Given this list of marker genes JPT1, RAN, DBI, RPS7, POMP, TMSB10 (NCBI Gene Id 9168), PSME2, PPIA, ANXA2, COX6B1, ATP5ME, NPM1, SUB1, TXN, SSR3, CLIC1, POLR2L, ATP5PO, ATP5MC3, NME1, NOP10, GLRX, SEC61B, LSM3, COX6C, SNRPG, PPIB, BTF3, PDIA6, TMA7, CHCHD2, NDUFS5, HMGB1, COX7A2, IGHA1, SNRPD2, ATP5PF, PPA1, H2AZ1, NDUFB3, COX7B, ATP5MF, CYCS, HSPE1, JCHAIN, SSR2, PRDX1, LGALS1, UQCRH, PTMA, here is a description of the gene set: Genes upregulated in subsets of cells of a given type within various tumors Human Gene Set: GAVISH_3CA_METAPROGRAM_B_CELLS_RESPIRATION In this study, an extensive analysis was conducted to define meta-programs (MPs) capturing intra-tumor heterogeneity across a spectrum of tumor types. The approach utilized non-negative matrix factorization (NMF) to analyze each cell type separately within individual tumor samples. This involved the analysis of malignant cells, macrophages, fibroblasts, endothelial cells, epithelial cells, T-cells, and B-cells. NMF was executed with varying parameter values (K=4, 5, 6, 7, 8, 9), thereby generating 39 programs for each cell type per sample. Each NMF program was summarized by the top genes based on NMF coefficients.\nRobust MPs were then delineated for each cell type using a set of stringent criteria, including recurrence within the same tumor, similarity to programs in other tumors, and non-redundancy within a tumor. Subsequently, these robust NMF programs were clustered (per cell type) based on Jaccard similarity, leading to the identification of MPs associated with each cell type.\nTo enhance the quality of the MPs, a refinement steps were undertaken, involving the removal of MPs suspected of reflecting low-quality data (with an overrepresentation of ribosomal proteins or mitochondrial-encoded genes), single-study inclusion, or similarity to miss-annotated cell types. studied in species Homo sapiens from publication Gavish A, Tyler M, Greenwald AC, Hoefflin R, Simkin D, Tschernichovsky R, Galili Darnell N, Somech E, Barbolin C, Antman T, Kovarsky D, Barrett T, Gonzalez Castro LN, Halder D, Chanoch-Myers R, Laffy J, Mints M, Wider A, Tal R, Spitzer A, Hara T, Raitses-Gurevich M, Stossel C, Golan T, Tirosh A, Suvà ML, Puram SV, Tirosh I (PMID 37258682)